Given this list of marker genes MIF, NPC1, VPS4A, IRF2BP2, GABRD, GNPTAB, ACSL5, SMARCD1, TWNK, FADD, LIMK1, HGD, CALR, IFT80, MECOM, IFT172, SEMA4A, MT-ND5 (NCBI Gene Id 4540), ATP7A, SPTA1, SLCO1B1, PIEZO1 (piezo type mechanosensitive ion channel component 1 (Er blood group)), MT-CYB, PIGA, FBP1, GPC3, LZTFL1, POT1, IL17F, POMC, SCN4A (sodium voltage-gated channel alpha subunit 4), ITCH, SBDS, NFS1, HYMAI, UROD, USP18, SLC39A4, CYP7B1, SLC25A1, UGT1A1, STAT1 (NCBI Gene Id 6772), LYN, ZFTA, PRIM1, INSR, SOX10, TOGARAM1, MRPS7, FARSB, SLX4, BBS4, CD19, OCLN, LYST, NPC2, PPP1R21, NHP2, RFXAP, C2orf69, MKKS, POLG, RAC2, LZTR1, ADAMTS13, PCK2 (phosphoenolpyruvate carboxykinase 2, mitochondrial), CTNS, MT-ND2, C1QBP, NAA10, ITPR1, IER3IP1, CPT1A, NHLRC2, CD79B, HBA1, TNFSF11, ASAH1, MYRF, SCLT1, CEP164, GPD1 (NCBI Gene Id 2819), GNS, SKI, TRMU, NELFA, LPL, CD81, BAAT, NDUFA6, PTPN22 (NCBI Gene Id 5779), MET, ASXL1, BBS2, CEL, TNNT2 (NCBI Gene Id 7139), ROS1, TKFC, GDF2, EARS2, FANCB, HADHA, ATP6AP1, MCTS1, LBR, NCF2, DNAJC30, RAG1 (recombination activating 1), ATP5F1E, MICU1, GCK, INPP5E, SFTPA2, TRIP13, DCDC2, ENG, ABCG8, PGM1, GLIS3, PC, CCDC47, SUCLG1, B9D2, DUOXA2, SDCCAG8, BAZ1B, GATA2, GAA, IDS, ZPR1 (NCBI Gene Id 95155), IGKC, MTR, MRPS28, POU1F1, CIITA, PEX12, TFR2, NDUFAF4 (NADH:ubiquinone oxidoreductase complex assembly factor 4), SLC22A5, LHX4, MT-ND4, KIF12, PRDM16, IRF5, MYL2, LIG4, MAP2K1, PCYT1A, ABCD1 (ATP binding cassette subfamily D member 1), NDUFS7, KCNN3, TALDO1, NDUFV2, TRAPPC11, BLVRA, TTC7A, PIGL, SLC39A8, CLDN1, PYGL (NCBI Gene Id 5836), RUNX1, SLC25A15, STEAP3, TG, TGFBR2, MT-TV, LTBP3, CD3D, SH2D1A, DLK1, PTRH2, SPIB, TSHR, HYOU1, RFX6, SERPINC1, FGA, IGF2, APOE, TNPO3, RRM2B, STOX1, NDUFAF3, NOTCH2, MMUT, DPM1, SASH3, CEACAM6, FCGR2A, ARG1, MT-ATP8, RMRP, BLK, FAM111B, ZFYVE19, BBS7, BICC1, CTCF, JAG1, DOCK11, CD96, RASGRP1, SDHA, MLH1, RFC2, FGFR2, SUMF1, PARN, B2M, TERT, CLCN7, SEC23B, SCAPER, NOP10, TBL2, KRAS, TBX19, ATP5MK, AMACR, MMACHC, RAG2, CEP19, STK11, SAMHD1, SLC4A1, TSC2, SMAD4, VPS37D, PIGG, PNPLA2, GTF2I, SCNN1A, MED25, STIM1, DDOST, APC, CEACAM3, PRDX1, LSM11, COMT (NCBI Gene Id 1312), IL2RG, FKBP6, NEUROD1, GLRX5, TMEM70 (NCBI Gene Id 54968), TGFB1, CASZ1, STXBP2, ABCC6, FDX2 (ferredoxin 2), HBB, AGL, AGA, TMEM216, TMEM237, JMJD1C, BTNL2, DPF2, BLNK, ATP6V1B2, TUFM, ADAR, KRT18, ADAMTSL2, XPR1, MST1, AIRE, DDRGK1 (DDRGK domain containing 1), TULP3, ACADM, G6PD, ABCC2, TFAM, ETFA, TMEM107, TXNDC15, GALE, TMEM126B, SOCS1, SLC38A3, RTL1, RHD, GCLC, DIS3L2, SLC35C1, PPOX, SON, CTRC, COX15, ARSA, GPC4, CYP2R1, FANCI, TF, BRCA1, CCND1, FANCA, FANCE, SLC25A19, HAVCR2, SMARCA4 (SWI/SNF related, matrix associated, actin dependent regulator of chromatin, subfamily a, member 4), ATP6AP2, PRSS1, ANK1, DNASE2, MKS1, BBS10, COX5A, FOXF1, GUCY2D, RIT1, ZNFX1 (NCBI Gene Id 57169), RPGRIP1L, CDKN1C, RNASEH2C, GNMT (glycine N-methyltransferase), NEU1, CLEC7A (NCBI Gene Id 64581), LONP1, HPGD, TNFSF15, HEXB, KIT, MYBPC3, XK, SLCO2A1, DPAGT1, DHDDS, ATRX, APPL1, DNASE1L3 (deoxyribonuclease 1L3), ACAT1, CD55, LETM1, PSMB8, PDCD1 (NCBI Gene Id 56179), NDUFAF1, PMS2 (PMS1 homolog 2, mismatch repair system component), DHCR7, INPPL1, XRCC2, LMNA, HBG1, DLD, MT-ND6, SLC17A5, TRAF3IP1, AHDC1, GBE1, SRSF2, HLA-DRB1, PSMB9, RHAG, PDE11A, SDHB, NDUFS8, GFM1, STX1A, ATAD3A, PRKCZ, CTC1, PALB2, CNTNAP2, SGSH, LDLRAP1, WDPCP, KCNJ11, PLAGL1, LUZP1, INVS, BCHE, HNF1A, PPARG, CPA1, CTSC, SPI1, ABCA1, GTF2IRD2, TP53, PRPS1, B9D1, PLIN1, UBE4B (ubiquitination factor E4B), CFAP418, BBS9, SYK, KCNQ1 (NCBI Gene Id 3784), BAP1, AP1B1, XRCC4, ABCD3, ABCB11, TNFRSF13C (NCBI Gene Id 115650), UFD1, TNNI3, ACOX1, PTEN (NCBI Gene Id 8037), FUCA1, MVK, CYP19A1, NDUFS6, CASK, ITK, UNC45A, PCCB, MTRR, HFE, IARS1, ICOS, HNRNPA1, DHFR, MLXIPL, INS, AXIN1, PKD2, RNU4ATAC, CTSA, SLC2A1, AHCY, NDUFAF8, RERE, FANCC, H19, LMBRD1, MT-TE, METTL27, HMGCL, SEC24C, CD3E (NCBI Gene Id 916), HADHB, BRCA2, VPS50, IGF2R, PHKA2, FASLG, PIK3R1, CBL, PEX13, NCF1, JAM3, PKD1, RABL3, ALG9, TCF4, NSD2, ABCB4, CDKN1B, LIPE, LIPA, SCNN1B, GPIHBP1, STAT4, UQCRFS1, BBS5, MAPK8IP3, BMPR1A, NRAS, TRPV6, LARS1, ATP11C, PIK3CA, CYP27A1, PSMB10, NDUFS3, CPT2, HIRA, ACVR2B, TRHR, PHKG2 (phosphorylase kinase catalytic subunit gamma 2), RPS20, WT1, TYMS (NCBI Gene Id 7298), MED12, STX5, GANAB, LAMA5, ATP7B, LHX3, KDM5C, BRAF, IL6ST, PSAP, GNAS, PLAAT3, ASS1, GLB1, NBAS, RMND1, NOD2, PEPD, VIPAS39, ACADS, PSMG2, TPP2, COG8, TNFRSF13B, IGHG2, BMP6 (bone morphogenetic protein 6), KMT2D, PEX1, PLEKHM1, MT-TW, TMEM165, PEX11B, CASP8, SETBP1 (NCBI Gene Id 284262), CPLX1, NSD1, VHL, PIK3CD, UNC13D, GCDH, TERC, ELN, MARS1, G6PC3, STX11, HMOX1, ADA, FLT1, COX4I2, PTPRC, ATP5F1A, ESAM, CD28, COG6, IYD, PCK1, FBXL4, STAT3, PTPN2, ALG13, ERCC6, TRMT5, UBR1, IL36RN, CCDC115, PIGS, NFKB1, HK1, MFN2, NDUFAF5, SLC5A5, SLC51B, RNASEH2B, SCNN1G, SLC25A13, FCGR3B, IFT43, MCM4, PAX8, TCF3, AGR2, SF3B1, KDM1A (NCBI Gene Id 23028), TRIM37, HSD3B7, STN1, PRKCSH, C4B, MSH2, RNU7-1 (NCBI Gene Id 100147744), CAV1, SLCO1B3, SCO2, DGUOK, NAE1, ALMS1, SLC30A10, HCK, TRIM32, SEMA7A, PDX1, CPOX, SMARCB1, IRAK4, AKR1D1, KLF1, XYLT1, NDUFV1, IFNGR1, PMS1, ATP8B1, HBG2, USP53, CLIP2, FANCM, ASL, ENPP1, CDIN1, RECQL4, SAA1, PEX16, ATPAF2, CBS, PCSK9, SLC16A2, CARS2 (cysteinyl-tRNA synthetase 2, mitochondrial), B4GALT1, NDUFAF2, JAK2, TPI1, ARSB, TSHB, TTC21B, HTRA2, GATA6, ARL6, MYORG, POLR3A, NPHP3, SNX10, ALDH1A2, CHD7, TYMP, MYD88, ALDOB, AP3D1, MT-ND1, ARID1B, ARVCF, HJV, MS4A1, PALLD, NAB2, LYZ, PRF1, EPB41, EFL1, TLR8, NDUFA1, VPS11 (NCBI Gene Id 55976), PI4KA, KIF23, PFKM, TCTN1, IL18BP, TPO, GALK1, AUH, AP3B1, TSFM, SDHD, GSTM3, HAMP, BBIP1, RIPK1, STAT6, SLC26A9, ACADVL, HSD17B4, ERCC4, PROP1, NLRP3, ALG2, CLPB, CYP7A1, FOXP3, LDLR, ZAP70, CEP290, DNAJC19, ZFX (zinc finger protein X-linked), FLI1, DYNC2LI1, FOXE1 (forkhead box E1), EPCAM, PTPN11, SNX14, ABCC8, SLC25A4, MUTYH, CIDEC, MPL, TNFRSF1B (NCBI Gene Id 7133), CTLA4, CFTR, XIAP, SHPK, IFT122, PNPLA6, DYNC2I1, FOXN1, DOCK6, SUPT16H, SCYL1, DCTN4, MYO5B, KIF3B, SLC7A7, PCCA, VPS45, BBS1, ALDOA, BMPER, SLC19A1, NGLY1, GPR35, MAN2B1, PIGM, SLC37A4, ADRA2A, FAS, SLC2A2, TCN2, IL2RB, HMBS, RINT1, BCAP31, IL12A, CYBB, PEX3, MOGS, ZNF699, MEG3, KMT2B, SLC11A2, NFKB2, MCCC1, PKLR, NPHP4, FTH1, SOX11, FOS, MADD, CC2D2A, TTC8, GPR101, IL12RB1, AIP, CA2, MRPL39, RORC, SERPINA1, EIF4H, NAGS, NAGA, SPOP, APOA1, MICOS13 (NCBI Gene Id 125988), SOS2, MECP2, IGHM, FANCF, LYRM4, PDGFB, ACAD9, HEPACAM, ESCO2, APOC2, PSMB4, MYPN, NUBPL, CD27 (NCBI Gene Id 939), IDUA (alpha-L-iduronidase), PERCC1, NLRP1, MRPL44, SLC10A1, NCF4, FERMT3, RPGRIP1, IQCB1, KCNQ1OT1, SPIN4, COA8, DVL1, SP110 (SP110 nuclear body protein), FOXRED1, MPI, HSD17B10, ACVRL1, RNF43, PCSK1, ERCC8, NDUFB11, BMP2, MMEL1, SLC26A4, ABCG5, CAVIN1 (caveolae associated protein 1), ACTG2, COG5, CNOT1, IL17RC, GALNS, SLC44A1, CA5A, CHEK2, TMEM67, TNFSF12, HADH, IL7R, JAK3, MT-TN, LRRC8A, DUOX2, MT-TL1, CTSK, DYNC2H1, DOCK8, PHKB, ALG5 (ALG5 dolichyl-phosphate beta-glucosyltransferase), SPEN, FTL, GPI, NDUFA2, KRIT1, HBA2, RFX5, IL6, SLC39A7, RBCK1, IFT56, PRKCD, EOGT, CDAN1, VCP, LRPPRC, ARHGAP31, BOLA3, NPM1, NCKAP1L, FGFRL1, NDUFB10, SURF1 (NCBI Gene Id 6834), NR1H4, SCO1, IFNG, RAB27A, GTF2IRD1, DYNC2I2, UBE2T, BBS12, KCNH1, COG4, RFT1, SLC29A3, CYP27B1, SLC51A, TCTN3, ATM, TIMMDC1, MT-ND3, GIMAP5, FH, CASP10, IFT140, SOX4, LCAT, ACBD6, COG7, SRP54, FANCL, CREBBP, RASA2, REL, GP1BB, PIK3C2A, FARS2, KPTN, IFIH1, SMPD1, MMAB (metabolism of cobalamin associated B), ABCA12, OTUD5, SKIC2, PDPN, LACC1, SLC20A2, TNFRSF1A, RNASEH2A, PDGFRL, ALG1, PIK3CG, SPINK1, AKT2, CSPP1, MRAS (muscle RAS oncogene homolog), IKBKG, SEMA4D, CD247, FARSA, DKC1, OSTM1, IRF1, VPS33B, GNE, SPRTN, NAF1, SLC34A2, IL1RN (interleukin 1 receptor antagonist), RRAS, KCNN4, ALG6, PARS2, UCP2, ARID1A, RFWD3, NKX2-1, ZIC3, C1S, LMNB2, FANCD2, ARID2, BLM, SPRED2, DPM2, IGLL1 (NCBI Gene Id 8222), CD79A, TSC1, GBA1, MPV17, COG1, MMP23B, ARPC5, GH1, EPB42, TARS2, NDUFS4, POLD3, SDHC, AP1S1, GALT, MRPL3, HNF1B, TREX1, SPTB, FECH, CORIN, IL2RA, MTTP, CR2, GALM, SMARCE1, RAD51, ARL13B, TFE3, RBM8A, NEK8, PEX19, GNB2, JAK1, DCLRE1C, CTNNB1, SLC6A14, TOMM7, SH2B3, F5, UROS, LRP5, CLCA4, ACP5, NFKBIA, NDUFB3, MYC, HESX1, COX14, IRF4, PAX4, NPHP1, RAD51C, CD70, GCGR, ADA2, TINF2, POU2AF1, IRF8, TMEM199, ABHD5, SLC11A1, POLD1, ARMC5, POLE, USP9X, SPTBN1, CD40LG, POU6F2, EP300, SLC25A20, AGGF1, BUD23, ALAS2, HNF4A, FLNC, RAF1, IFT27, BRIP1, PEX14, DNAJB11, SKIC3, KYNU, PUS7, ANTXR1, EXTL3, WRAP53, HMGCS2, BTD, TET2, NOTCH1, PDGFRA, SC5D, TCIRG1, TRIM28, GUSB, RRAS2, KCNAB2, HNRNPA2B1, JAM2, TCTN2, PTPN3, RREB1, ETFDH, SMARCC2, PEX10, SOS1, PEX6, PEX5 (peroxisomal biogenesis factor 5), NDUFS1, NSMCE2, TKT (transketolase), FAH, CEP83, KMT2E, MT-ATP6, TJP2, ERBB3, KIAA0753, DLL4, ADK, TMEM231, UQCRB, CDKN2A, ERCC1, NEK1, RHCE, PKHD1, DNAJC21, KIF20A, MUC5B, SCARB2, SAR1B, MTX2, TMEM270, CTBP1, MMAA, KLF11, PEX2, CYBA, NEUROG3, MPC1, RBPJ, NDUFB9, CEP120, APC2, MEFV, NAGLU, OFD1, LIG3, TBX1, B3GLCT, SEC63, NDUFS2 (NADH:ubiquinone oxidoreductase core subunit S2), DMPK, NDUFA11, FBN1, EWSR1, LPIN2, SHARPIN, PSTPIP1, NKX2-5, HGSNAT, BTK, YARS1, EDNRA, EIF2AK3, PMM2, ATP5F1D, TRAF3IP2, HSPG2, APOB, BSCL2, FOCAD, CCDC28B, CP, ETFB, MSH6, VPS13A, POLG2, ANKRD55, DZIP1L, DOCK2, VPS33A, SLC9A3, SFTPC, PRKAR1A, USB1, REST, DEF6, ANKS6, IL17RA, MT-TK, YARS2, TRAC, AGPAT2, TNFRSF11A (NCBI Gene Id 8792), SLC40A1, CASR, PRSS2, CYBC1, ALG8, IL21R, RHBDF2, GYPC, RTEL1 (regulator of telomere elongation helicase 1), WDR19, HOXD13, FANCG, MAGT1, RFXANK, G6PC1, PDGFRB, MAD2L2, INTU, BCS1L, IFT74, PHEX, WDR35, PEX26, here is a description of the gene set: Abnormality of the liver species: Homo sapiens Human Gene Set: HP_ABNORMALITY_OF_THE_LIVER An abnormality of the liver.